Given this list of marker genes KCTD2, KLHL35, KLHL42, RBX1, KCTD17, GAN, KCTD13, PDCD6, ARIH1, KLHL18, KLHL24, TNFAIP1, KEAP1, KLHL41, LZTR1, DEPDC5, CUL3, KLHL15, KLHL2, KBTBD3, KLHL6, SPOPL, KLHL28, ENC1, KLHL3, KLHL30, KLHL7, KLHL12, IVNS1ABP, KCTD5, KLHL20, KBTBD6 (NCBI Gene Id 89890), KBTBD2, KLHL22, KLHL40, IPP, KLHL38, SPOP, KLHL9, KLHL4, KLHL25, KLHL21, ZSWIM8, KLHL11, KLHL13, KLHL29, GLMN, KLHL8, KLHL23, KLHL10, KLHL17, KBTBD7, KBTBD8, CCIN, KLHL1, KCTD10, PEF1, KBTBD12, ARMC5, KLHL5, here is a description of the gene set: species: Homo sapiens A ubiquitin ligase complex in which a cullin from the Cul3 subfamily and a RING domain protein form the catalytic core; substrate specificity is conferred by a BTB-domain-containing protein. Human Gene Set: GOCC_CUL3_RING_UBIQUITIN_LIGASE_COMPLEX